Given this list of marker genes OSR1, ZNF644, FMNL3, MINDY2, CAB39, MEX3C, SAMD4B, AKTIP, YTHDF2, EMSY, YWHAZ, OGT, here is a description of the gene set: Genes having at least one occurence of the motif AACGGTT in their 3' untranslated region. The motif represents putative target (that is, seed match) of human mature miRNA hsa-miR-451 (v7.1 miRBase). Human Gene Set: AACGGTT_MIR451 studied in species Homo sapiens